Given this list of marker genes DCK, DPYS, DPYD, UCK1, UCK2, UPP1, UPP2, UCKL1, UPB1, here is a description of the gene set: The chemical reactions and pathways involving CMP, cytidine monophosphate. Human Gene Set: GOBP_CMP_METABOLIC_PROCESS species: Homo sapiens